Given this list of marker genes TMEM95, ANKRD13A, AMMECR1, FAM219A, DOK1, RSPRY1, KIAA2013, DCTN5, CD34, IL31RA (interleukin 31 receptor A), TCF7, GFAP, MTCL2, SPRED1, LARGE1, IRAK2, SLC2A3, BCL9, PHB2, CASP9, MTUS2, DSN1, CNOT9, MAP3K9, AGTPBP1, TGFBR2 (NCBI Gene Id 7048), DENND2B, BDNF, TFB1M, TMEM121B, ACOD1, FCRL4, THBS3, SIKE1, HIP1, ABLIM2, ZNF140, GALNT11, SMC3, ZNF397, CDC37L1, LASP1, CYTL1, GABPB1, BICD2, SNURF, HSD17B8, GABRA1, TWIST2, ATRN, PPBP, CACNB1 (NCBI Gene Id 782), SYN3, HS1BP3, OXSR1, TRIM49C, KCNE3, LRRC38, DSG1, CLCN6 (chloride voltage-gated channel 6), CISH, KLHL42 (kelch like family member 42), ADAMDEC1, CLEC1A, PPP2R2C, CREB3L1, PLXNA4, ATXN7L3, ERF, KHDRBS1, CTSA, PSENEN, URGCP, B3GNT7, IGFBP5, TMEM266, ANKRD54, NXF1, NPTX1, MUSTN1 (musculoskeletal, embryonic nuclear protein 1), A1BG, PPP1R1B, LILRB2, ZNF704, NMNAT3, KBTBD2, SYNJ2BP, PAX7, CLDN9, TANC1, CYB5RL, MINK1, CASP2, EFNB1, GASK1B, SCN2B, BEND4, KDM3B, PAPPA, DLGAP3, DNAAF11, AFAP1, PCBD1, VAPB, CBX5, AIFM3, ARRB1, FBXO36, EGFR, RAB5B, S100A7A, MED19, PALM2AKAP2, SLC25A36, TRAK1, STIMATE-MUSTN1, BLTP3A, AMN1, NRF1, BTRC, IL18BP, HYCC2, USH1C, ANKRD24, DRG2, ATG7, XKRX, PLEKHG4B, KSR2, CELSR2, TRIM49, XKR4, TMEM253, NIPAL3, NDEL1, SYNGR1, ARHGAP35, PEPD, BMF, KPNA6, SLC23A2, SLC2A14, CPNE2, ADARB2, PLXDC2, KDR, C15orf39, RASA2, ADD2, PTPN4, NR2C2AP, THOC7, RPP14, KCNA5, PTPRT, QSER1, TGFBR1, CNOT3, LARP1, HIPK1, RNF2 (ring finger protein 2), PLEKHM3, EPHB3, L1CAM, MYO18A, DTNB, TNPO3, SYNJ1, STK4, THAP6, TRIM35, MTR, HOXA7, MAU2, PIK3C2A, TOB2, IFIT5, UBE3B, PTPRJ, SIAH3, TBC1D16, SLC41A1, ABCC1, PPP4R1, TEAD4, TMIGD3, FOXC1, VPS37D, SEL1L (NCBI Gene Id 6400), PRKRIP1, SOX10, TP73, TPM4, AGAP1, ZNF555, ALPL, SYNPO2L, SHISA7, IFNGR2, CHI3L2, EXD2, SLC7A6, RER1, CAMK1D, ITGA5, PYROXD2, ELMO2, BPIFC, MTF1, here is a description of the gene set: Human Gene Set: MIR6783_3P from publication Chen Y, Wang X (PMID 31504780) Genes predicted to be targets of miRBase v22 microRNA hsa-miR-6783-3p in miRDB v6.0 with MirTarget v4 prediction scores > 80 (high confidence targets). species: Homo sapiens